Given this list of marker genes LGALS9, VSIR, FOXP3, SLC4A2, ARG2 (NCBI Gene Id 384), CD274, LGALS9C, LGALS9B, CLEC4G, TWSG1, ZBTB7B, CBLB, XCL1, TNFRSF14, ITCH, NDFIP1, here is a description of the gene set: Any process that stops, prevents, or reduces the frequency, rate or extent of alpha-beta T cell proliferation. Human Gene Set: GOBP_NEGATIVE_REGULATION_OF_ALPHA_BETA_T_CELL_PROLIFERATION studied in species Homo sapiens